The following is a description of a gene set: electronically inferred by orthology from the curated human pathway part of: Interleukin-12 family signaling studied in species Mus musculus This event has been computationally inferred from an event that has been demonstrated in another species.<p>The inference is based on the homology mapping from PANTHER. Briefly, reactions for which all involved PhysicalEntities (in input, output and catalyst) have a mapped orthologue/paralogue (for complexes at least 75% of components must have a mapping) are inferred to the other species. Reactome Pathway: Interleukin-23 signaling, and this is the list of marker genes: Tyk2, Stat4, P4hb, Il12b, Il23a, Il23r